Given this list of marker genes ADCY7, CXCL12, OXT, CES2, CDHR1, ATP5PD, GGCX, P2RY14, APOBEC2, UBL3, SDC3, SEMA3A, NCKAP1L, SAMM50, ADARB1, KTN1, DKK1, YLPM1, P2RX1, POLR2G, DNASE2, ETV5, TMPRSS15, MAPK14, BAX, CAMK1, GGA2, ADH7, KCTD12, SORL1, SRPX2, PLCG2, DOK2, BAP1, SPRY1, BRPF1, RNF6, S100A4, BAG5, SDC2, CACNA1S, SULT2A1 (sulfotransferase family 2A member 1), GSTZ1, LPL, SLC9A6, ADAM12, TES, ERF, CLEC11A, TXNIP, CPVL, MAF, HCCS, ABL1, APOC1, PECAM1, HHEX, KCNS3 (NCBI Gene Id 3790), USP6, ZNF391, VASH1, HMGXB3, PPM1F, LYL1, PPY, PFDN5, DOCK2, STAC, SULT1A1, MDM2, STAB1, ODF2 (NCBI Gene Id 4957), LILRA2, TRIB2, TAX1BP1, LINC01587, CA4, GPR143, COX6B1, AOPEP, SYT2, ZBTB1, PFKFB4, TTC9, NRGN, MACROH2A1, DPYD, EXOSC9, ATXN1, RIN2, CHN2, FABP6, CLEC2B, ITGB1BP1, SLC19A1, OSBPL1A, RAB11FIP2, PDIA4, SCG2, NOL3, IDH1 (NCBI Gene Id 3417), STX10, AHCY, UQCRC1, OVOL2, PLA2G15, PIKFYVE, RXRA, RCBTB2, APOC2, PCF11, MSR1, TMT1A, F13A1, RAB14, ZCCHC24, VAMP8, CACNA1E, VCL, HEXB, CD1B, LPCAT4, CRABP2, TUSC2 (tumor suppressor 2, mitochondrial calcium regulator), FUCA1, CORO2A (coronin 2A), S100A13, SERINC5, CTNNAL1, LRRTM2, HNMT, RETREG3, GGA3, CDC42EP1, TPM1, MED8, ITPKB, MYL4, CAPN11, TGFBR2, CD52, PINK1, AIFM1, CASR, GPX3, ALOX5, CRTAM, GATD3, MKRN1, KIAA0232, PRCP, ITPR2, G6PC1, ADORA3, ARHGEF18, FAM131A, ZDHHC17, PNPLA6, HFE, RNASE6, TGOLN2, FKBP8, SORBS2, SUPT7L, MYH9, C3AR1, KCNB1, CD1E, GBX2, RRP1B, FOLR2, TCEAL4, FARSA, ELL, PEG10, LTA4H, PIP4K2B, EGR2, DIAPH1 (diaphanous related formin 1), EHMT2, MGST2, EFCAB14, KRT75, ESYT1, TNFSF12, INPP5D, INTS9, SPON1, KRT15, ATP5MC1, MID2, PICALM, KLRB1 (NCBI Gene Id 3820), ALDH3B1, MCAT, MEGF8, PTGES, DOCK1, ADIPOQ, here is a description of the gene set: from publication Chaussabel D, Semnani RT, McDowell MA, Sacks D, Sher A, Nutman TB (PMID 12663451) studied in species Homo sapiens Monocyte-derived dendritic cells (DC) and macrophages (MΦ) generated in vitro from the same individual blood donors were exposed to five different pathogens, and gene expression profiles were assessed by microarray analysis. Responses to Mycobacterium tuberculosis and to phylogenetically distinct protozoan (Leishmania major, L. donovani, Toxoplasma gondii) and helminth (Brugia malayi) parasites were examined, each of which produces chronic infections in humans yet vary considerably in the nature of the immune responses they trigger. Genes up-regulated in untreated dendritic cells (DC) versus DCs exposed to parasite Toxoplasma gondii. Human Gene Set: GSE360_CTRL_VS_T_GONDII_DC_UP